The following is a description of a gene set: species: Homo sapiens Human Gene Set: HP_ABNORMAL_HAIRSHAFT_MORPHOLOGY An abnormal structure of the hairshaft, i.e., of the nongrowing portion of a hair that protrudes from the skin. Abnormal hairshaft morphology, and this is the list of marker genes: SKIC2, DSG4, MPLKIP, GAN, PADI3, BCS1L, NECTIN4, KRT25, SPINK5, PEX1, ERCC2, HEPHL1, TP63, CARS1, ASL, MARS1, GJA1, TGM3, CDH3, LMNA, SKIC3, ERCC3, WRN, GTF2H5, PEX6, RNF113A, KDF1, ST14, CLCN6, TCHH, ATP7A, TARS1, GTF2E2, AARS1, KRT85, NECTIN1